Given this list of marker genes Col3a1, Gnrh1 (NCBI Gene Id 239161), Gpr173, Nrg3, Adgrg1, Gsk3b, Srgap2, Nrg1, Nexmif, Drd2, Tnn, Stat3, here is a description of the gene set: studied in species Mus musculus Mouse Gene Set: GOBP_NEGATIVE_REGULATION_OF_NEURON_MIGRATION Any process that stops, prevents or reduces the frequency, rate or extent of neuron migration.